Given this list of marker genes Ormdl1, Atg7, Rtn4, Ormdl3, Ormdl2, Abca2 (ATP-binding cassette, sub-family A member 2), here is a description of the gene set: studied in species Mus musculus Mouse Gene Set: GOBP_INTRACELLULAR_SPHINGOLIPID_HOMEOSTASIS A homeostatic process involved in the maintenance of a steady state level of sphingolipids within a cell.